The following is a description of a gene set: species: Mus musculus Hemostasis Mouse Gene Set: REACTOME_HEMOSTASIS, and this is the list of marker genes: Ighv5-4, Ighv3-8, Kifc1, Dock5, App, Orm2, Ptpn11, Ppp2r5b, Serping1, Wdr1, Abhd6, Vwf, Timp3, Atp1b3, Igkv8-21, Tubal3, Ppp2r5d, Klkb1, Gata4, Egf, Igkv2-112, Cd48, Mfn1, Rad51b, Apob, Dgki, Serpina3f, Cenpe, Ehd2 (EH-domain containing 2), Hras, Rasgrp1, Dok2, Pcyox1l, Ighv8-4, Kng2, Bcar1 (NCBI Gene Id 12927), Pde2a, Hgf, Cd109, Cd84, Rap1a, Ceacam1, Vav2, Ighv13-2 (immunoglobulin heavy variable 13-2), Kif20b, Atp2b3, Clec1b, Dock1, Daglb, H3c7, Serpinf2, Ahsg, Pdgfb, Sdc3, Itpr3, Tuba3a, C1qbp, Jaml, Kif3a, Ighv7-3, Hmg20b, Jak2, Tuba1c, Kras, Src, Gnb2, H3c11, F2rl3, Mif, Kif19a (NCBI Gene Id 432612), P2rx4, Rhoa, Plat, Cyrib, Proc, Dgkd (NCBI Gene Id 98439), Nhlrc2, Scg3, Kif4, Tfpi, F2r, Sirpb1b, Lyn (NCBI Gene Id 99963), Hrg, Kif20a, F12, Grb14, Ighv7-2, Adra2a, Akap1, Serpind1, Kif21a, H3c13, H3c10, Vav1, Racgap1, Apoa1, Tagln2, Ppp2r5a (NCBI Gene Id 226849), Itga6, Glg1, Tnfrsf10b, F8, Sele, P2ry1, Tgfb2, P2rx3, Ola1, Plaur, Pros1, Stxbp2, Actn1, Itpr1, Gata3, Adra2b, Ighv3-4, P2rx2, Igha (immunoglobulin heavy constant alpha), Spp2, Slc16a3, Pdpn, Apool, Grb7, Crk, Kif3b, Alb, Igkv18-36, Gp9 (glycoprotein 9 platelet), Igkv17-121, Tek, Igkv1-110, Atp1b1, Tubb2a (tubulin, beta 2A class IIA), Mapk1, Actn4, Gp5, Igkv1-35 (NCBI Gene Id 637047), Hdac1, Gnai3, F11r, Ighv5-9-1, Gas6, Plek, Cd74, Akt1, Ptgir, Ppbp, Lck, Inpp5d, Csk, Ppp2r1b, H3c1, Grb2, Maged2, Igll1, Ly6g6f, Serpina5, Spn, Lat, Ighv8-12, Igkv1-117, Dgkh, Syk, Sccpdh, H3c4, Orm3, Gnai2, Pde9a, Rac1, Clec3b, Sdc2, Chid1, Slc7a8, Kif1a, Itgam, Fermt3, Prkaca, F3, Mmrn1, Igkv20-101-2, Ighv5-16, Pik3r3, Psg29, Ighv5-12-4, Tubb1, Mmp1a, Calm2 (NCBI Gene Id 75700), Igkv15-103, Ighv5-17, Pcdh7 (protocadherin 7), Cav1, Prkch, Dgka, Kifc5b, Pik3ca, Jam2, Sri, Pik3cg, Akap10, Trem1, Igkv1-133, Shc1, Sirpb1a, Klc2, Bsg, Itgb2, Ighv6-6, Calm1, Cdc42, Igkv1-135, Angpt4, Rad51c, Kif2b (kinesin family member 2B), F7, Cd44, Kif18b, Vav3, F13a1, H3c6 (NCBI Gene Id 319151), P2rx6, Fgb, Lcp2, Gng4, Igkv1-88 (immunoglobulin kappa chain variable 1-88), Prkcq, F13b, Kifc2, Serpinc1, Tubb2b, Capzb, Slc7a10, Ighv8-2, Tgfb1, Tubb4a, Dagla, Ighv8-8, Ighv5-6, Ighv5-9, P2rx5, F5, Ighv5-15, Prcp, Cd9, Prkcb, Col1a1, Mag, Kif15, Kdm1a, Pde10a, Tor4a, Gng11, Cd36, Mapk14, Selp, Sell, Mpig6b, H3f3a, Gng2, Vegfb, Kif18a, Trpc7, Cyb5r1, F10, Itpk1 (NCBI Gene Id 217837), Habp4, Vegfa, Ak3, Ppp2r5c, Kif1c, Prkcd, Sod1 (NCBI Gene Id 319325), Plcg2, Vcl, Dock2, Serpinb8, Gng5, Selenop, Gp1ba, Prtn3, Ighv8-5, Ighv6-5, Gnas, Cd47, Pde1b (NCBI Gene Id 18574), Pafah2, Ppil2, Ehd1, Anxa5, H3c15, Gng12 (NCBI Gene Id 72111), Mapk3, Dock8, Zfpm2, Atp1b2, Ecm1, Serpine2, Ptk2, Fga, Vegfd, Angpt2, Olr1, Ighv6-4, Lhfpl2, Dock10, Aldoa, Kifap3, Gna13, Ighv3-6, Igkv16-104, Kif2a, Gna12, Slc16a1, Dgkk, Gnaq, Pecam1, Pik3cb, Ighv6-7, Kif21b, Ehd3, Zfpm1, Fyn, Pik3r6, Trpc3, Rhog, Cd177, Ighv8-11, Gna14, Igkv1-132, Prkar1a, Kif26b, Rab27b, Igf2, Ceacam2, Cxadr, Jchain, Gata5 (NCBI Gene Id 228988), Gngt1, Actg1, Rap1b, Rac2, Carmil1, Tln1, Adra2c, Aamp, Gng7, Gp6, Aplp2, Tuba1a, Ptpn6, Kif1b, Itgav, Rapgef3, Stxbp3, Tuba8, Pde1a, Kif9, H3c14, Kif5a, Gngt2, Nos3, Vps45, Itgb3, Pik3r5, Islr, Vegfc, Psg22, Tuba1b, Prkar1b, Rhob, Psap (NCBI Gene Id 19156), Fcamr, Dock4, Itih4, Trpc6, Prkg1, Ctsw, Pik3r2, Tubb6, Fgg, Mfn2, Rbsn, Slc7a7, Rapgef4, Itgb1, Thbs1, Abcc4, Igkv11-125, Kif12, Dgkb, Dgkg, Itpr2, Manf, Itga3, Calm3, Tuba3b, Gp1bb, Atp2b4, Gnb3, Serpina1b, Abhd12, Kif2c, Dgkq, P2ry12, Sdc1, Ighv5-2, Igkv1-122, Dock7, Slc7a9, Lefty2, Gnb4, Kif26a, Jmjd1c, Ptpn1, Selplg, Gng8, Tuba4a, Kif11, Timp1, Gata1, Srgn, Atp2a2, Slc8a1, Tgfb3, Kif27, Sh2b1, Fgr, Lefty1, H3c3, Dgkz, Igkv2-137, Dock9, Gpc1, Gata6, Atp2a1, Klc1, Actn2, Kif13b, Itgal, Cd63, Gm5150, Slc8a3, Slc7a5 (NCBI Gene Id 270102), Iglc1, Ywhaz, H3f3b, Prkcg, Capza2, Serpina1c, Fn1, Sirpd, Cd244a, Gna15, Sytl4, Iglc2, Prkacb, Apoh, Flna (filamin, alpha), F9, Serpine1, Pdpk1, Brpf3, Ighv8-6, Tmsb4x, Gng3, S100a10 (S100 calcium binding protein A10 (calpactin)), Fcer1g, Arrb1, Pf4, Psg18, Gtpbp2, Sirpb1c, Tubb4b, Apbb1ip, Plau, Anxa2 (annexin A2), Trf, Slc7a6, Kif6, Angpt1, Slc16a8, Pde5a, Sos1, H3c2, Serpinb2, Col1a2, Cdc37l1, Kif23, Igkv1-99, Atp2b2, Gnat3, Ppia, Rab5a, Gnb1, Phf21a (NCBI Gene Id 399586), Nos2, Igkv1-131, Pde11a, Ighv3-5, Tmx3, Dock6, Lrp8, Igf1, Tex264, Sh2b3, Vpreb3, Sh2b2, Gng13, Endod1, Jam3, Klc3, Slc8a2, Sdc4, Rarres2, Dock11, Ighv5-12 (immunoglobulin heavy variable 5-12), Yes1, Itga2b, Mertk, Atp2a3, Kif28, Pla2g4a, Cbx5 (chromobox 5), P2rx7, Thbd, Epcam, Klc4, Ighv3-3, Ppp2r5e, Pdgfa, Fam3c, Sirpa, Ighv8-9, Slc7a11, Mgll, Stx4a, F2, Kif22, Ighv12-3, Prkce, A2m, Ppp2cb, Lgals3bp, Gna11, F11, Phactr2 (phosphatase and actin regulator 2), Itih3, Ighv3-1, Vti1b, P2rx1, Tbxa2r, Serpinb6a (NCBI Gene Id 74999), Cfd, Esam, Kif16b, Raf1 (NCBI Gene Id 76876), Gnai1, Mafg, F2rl2, H3c8, Irag1, Qsox1, Ppp2r1a, Atp2b1 (NCBI Gene Id 67972), Rasgrp2, Gata2, Kif5b, Itga4, Maff, Igkv2-109, Plcg1, Nos1, A1bg, Gnb5, Vpreb1b, Kif3c (kinesin family member 3C), Dgke, Arrb2, Procr, Ighv16-1, Itgax, Clu (NCBI Gene Id 28201), Rcor1, Gng10, Slc3a2, Lamp2, Plg, Ighv8-13, Ighv6-3, Pik3r1, Ighv7-4, Sparc, Adamts13, Ppp2ca, Orm1, Itga5, Tubb3, Mafk